Given this list of marker genes OR51A7, OR56B4, OR1L8, OR5L2, OR5M8, OR10G9, OR52I2, OR4C46, OR14A16, OR4L1, OR10K1, OR5B17, OR52E1, OR51C1P, FZD2, OR1I1, GPR148, OR2AG2 (NCBI Gene Id 81337), GNAL, OR13C4, OR51E2, OR13J1, OR5B21 (olfactory receptor family 5 subfamily B member 21), OR52K2, OR8U9, OR7A10, TAAR9, OR1B1 (olfactory receptor family 1 subfamily B member 1), OR9A2, OR52I1 (olfactory receptor family 52 subfamily I member 1), OR51F1, OR51B6, OR2T5, OR1Q1, OR2G2, OR2M7, OR56A1, UGT2A1, OR4A47, OR6C65, OR4Q2, OR5AP2, OR4F3, OR7C1, OR14K1, OR2F1, OR2W1, OR1F2P, OR2Z1, PDE4A, OR2D3, OR5G3, OR6C6, OR12D1, OR5M3, OR51V1, OR6N1, OR8A1, GNAS, OR8G2P, OR10A7, OR1P1, OR52E6, OR2A42, OR4K15, OR9G9 (olfactory receptor family 9 subfamily G member 9), OR51A2, OR56A3, OR5M9, OR2G3, OR13A1, OR7A17, OR5M10, OR2I1P, OR5V1, OR9G1, OR5H8, OR2L3, OR2T27, OR4K14, OR4F6, OR8K5, OR5AL1, OR8G5, OR10W1, OR14A2, OR2M4, OR4N5, OR5K4, OR51S1, OR2M5, OR6C70, TAAR5, OR1A1, OR4E1, OR14C36 (olfactory receptor family 14 subfamily C member 36), OR10G2, OR5H14, OR4F21, OR6B2, OR1L1, OR51I2, OR51M1, OR1N2, OR52W1, OR5M1, OR1N1 (NCBI Gene Id 81367), OR2T29, OR8B12, OR51B4, OR2T7, OR9K2, OR52M1, OR5K1, OR8J3, OR8S1, OR14L1, ANO9, OMP, OR6Q1, OR52A4P, OR4F29, OR3A2, TAAR6, OR10H5, OR13C9, OR10H3, OR4F15, OR2A12, OR7G2, OR1L6, OR4C12, OR56B2P, OR10S1, OR10G6, OR51E1, OR2K2, OR5H2, OR13C2, OR51G2, OR5P2, OR8D1, OR10V1, OR6C76, OR1D2, OR4A4P, OR10A2, OR51F2 (NCBI Gene Id 81283), OR13C3, OR10K2 (NCBI Gene Id 79500), OR4D9, OR10G8 (olfactory receptor family 10 subfamily G member 8), OR4K13, OR4N2, OR5P3, OR52Z1P, OR1E1, OR13C6P, OR5B3, OR52K1, OR4E2, OR5H15, OR8H2, OR9A4, CFAP69, OR1J1, BBS1, OR6C74, OR10AG1, OR4K17, OR3A1, OR4A16, OR2S2, OR2T33, OR7A2P, OR3A3, OR8K3, OR6P1, OR52N5, OR4S1, OR7G1, OR4Q3, OR2J2, BBS4, OR51Q1, OR6X1, OR14I1, OR52B2, OR4D10, B3GNT2, OR5I1, OR10P1, OR11H6, OR2G6, OR10A5, OR4P4 (olfactory receptor family 4 subfamily P member 4), OR52B4, OR2J3, OR8J2, OBP2B, BEST2 (NCBI Gene Id 54831), OR5AK2, OR2V1, OR2A2, OR5AU1, OR7G3, OR5AC2, OR10J4 (olfactory receptor family 10 subfamily J member 4 (gene/pseudogene)), OR10J3, OR6C68, OR2A14, OR2L8, OR4D11, OR5W2, OR1E3, OR11H12, OR52E2, OR4C45, OR2A25, OR52H1, OR7C2 (NCBI Gene Id 26658), OR14J1, OR10G4, OR4M1, OR1G1, OR1J2, OR6K6, OR5H6, OR5K3 (NCBI Gene Id 403277), OR2W3, OR4D6, OR6T1, OR4C15, OR2AE1, OR1M1, OR2A5, OR1L4, OR13G1, OR13H1, OR52A1, NXNL2, OR52E8 (NCBI Gene Id 81263), OR10Z1, OR5B12, OR5D18, OR52R1, B2M, OR5AN1, OR7D4, OR10D3, OR13F1, OR2H2, OR11H4, OR6C2, OR1K1, OR2V2, OR8H3, OR51G1, CNGA2, OR2D2, OR1E2, OR2L2, OR11L1, OR6J1, OR4K5, OR5AS1, OR2T11, OR9A1P, OR2T34, OR1C1, OR6S1, OR51D1, OR2AG1, OR10H4, OR6C3, OR5T2, OR4D2, OR4C11, OR51B5, OR4D1, OR2A7, OR5B2, SLC24A4, OR51L1, OR2B11, OR8G3P, OR8G1, OR10X1, OR51A4, OR52N2, OR12D3, OR10A3 (NCBI Gene Id 26496), OR4M2B, UBR3, OR6M1, NAV2, OR2M3, OR4K2, OR5M11, OR2B6, OR52L2P, OR52E5 (olfactory receptor family 52 subfamily E member 5), OR4A5, OR2L13, OR1S2, OR2T1, OR2W5P, OR2J1, OR52A5, OR5AR1, OR6K3, OR4B1, OR52B6, OR8B8, GJB4, OR10J1, OR10J5, OR56A5, OR2Y1 (NCBI Gene Id 79489), OR2A4, OR10AC1, OR7E24, OR9I1, OR5H1, OR5D16, OR1A2, OR1F1, OR13C8, RIC8B, OR10A4, OR1F12P, OR4F16, OR10G7, OR2C1, OR4C6 (NCBI Gene Id 79319), OR4K1, OR10C1, OR51J1, OR2T3, OR5AK3P, OR4K3, OR2L5, OR6Y1, OR10J6P, OR4X2, OR12D2, OR4C16, OR5D14, OR2T10, DRD2, OR2A1, OR4N4, OR10A6, SYT10, OR1D4, OR2B2, OR52P1, OR56B1, OR10G3, OR2M2, OR4A8 (NCBI Gene Id 81315), OR7D2, OR51T1, OR9Q2, OR2C3, OR5A1 (NCBI Gene Id 26678), OR2AP1, OR56A4, OR6N2, OR8K1, OR11G2, OR8B3, OR52N4, OBP2A, OR6F1, OR2H1, OR5D13, OR11A1 (olfactory receptor family 11 subfamily A member 1), OR2T8, OR13D1, OR52J3, OR5K2, OR2W6P, OR8D2, OR4F4, OR2T35, OR11H1, OR4S2, CNGB1, OR8B4, OR5J2, OR6C4, OR11H2, TTC8, ADCY3, OR4C5, OR1L3, OR2T4, OR4C13, OR9Q1 (NCBI Gene Id 79326), OR5AC1, OR4C3, OR8J1, OR2B8P, OR2T6, OR8D4, OR2AK2, OR4X1, OR10H1 (NCBI Gene Id 26539), OR8H1, OR10Q1, OR10T2, OR2F2, OR13C7, OR13C5, OR52D1, OR10H2, OR11H7, OR51B2, OR4A15, OR2B3, OR8U3, OR5T3, OR6B3, OR5C1, OR52N1, OR7A5, OR1D5, OR5F1, OR8I2, OR2T2 (olfactory receptor family 2 subfamily T member 2), OR6C1, OR52E4, OR8U1, OR9G4, OR10R2, OR5A2, OR51H1, OR6C75, OR4F5, OR10D4P, SLC6A3, OR10AD1, OR1J4, OR2T12, OR1S1 (olfactory receptor family 1 subfamily S member 1), OR5T1, OR8B2, OR8U8, OR51I1, GFY, OR6A2, OR4D5, CNGA4, OR5BS1P, OR2AJ1, OR5L1, OR2AT4, OR4F17, OR6V1, OR52L1, OR4M2, OR6K2, OR6B1 (NCBI Gene Id 393045), MKKS, here is a description of the gene set: studied in species Homo sapiens Human Gene Set: GOBP_SENSORY_PERCEPTION_OF_SMELL The series of events required for an organism to receive an olfactory stimulus, convert it to a molecular signal, and recognize and characterize the signal. Olfaction involves the detection of chemical composition of an organism's ambient medium by chemoreceptors. This is a neurological process.